The following is a description of a gene set: A collagen trimer that associates with collagen fibrils and consists of collagen monomers that contain two or more relatively short triple-helical domains connected by non-triple-helical sequences. species: Mus musculus Mouse Gene Set: GOCC_FACIT_COLLAGEN_TRIMER, and this is the list of marker genes: Col12a1, Col9a2, Col9a3, Col9a1, Col13a1, Col16a1